The following is a description of a gene set: studied in species Mus musculus Mouse Gene Set: GOMF_TRANSFORMING_GROWTH_FACTOR_BETA_BINDING Binding to TGF-beta, transforming growth factor beta, a multifunctional peptide that controls proliferation, differentiation and other functions in many cell types., and this is the list of marker genes: Acvrl1, Wfikkn2, Wfikkn1, Chrdl1 (chordin-like 1), Lrrc32, Tgfbr3l, Twsg1, Acvr2b, Eng, Ltbp3 (NCBI Gene Id 16998), Tgfbr3, Hyal2, Tsku, Itgav, Tgfb3, Tgfbr2 (NCBI Gene Id 76304), Acvr1, Agrn, Tgfbr1, Vasn (NCBI Gene Id 74207), Nrros, Cd109, Ltbp1, Thbs1, Ltbp4, Cd36